The following is a description of a gene set: Mouse Gene Set: GOBP_AMINOACYL_TRNA_METABOLISM_INVOLVED_IN_TRANSLATIONAL_FIDELITY species: Mus musculus Any process which detects an amino-acid acetylated tRNA is charged with the correct amino acid, or removes incorrect amino acids from a charged tRNA. This process can be performed by tRNA synthases, or by subsequent reactions after tRNA aminoacylation., and this is the list of marker genes: Aarsd1, Dtd1, Lars1, Vars1, Dtd2, Iars2, Prorsd1, Lars2, Aars1, Iars1, Vars2, Tars2